The following is a description of a gene set: studied in species Homo sapiens Human Gene Set: REACTOME_REGULATION_OF_CDH11_GENE_TRANSCRIPTION Regulation of CDH11 gene transcription, and this is the list of marker genes: ZEB2, FOXF1, PRDM8, BHLHE22, HOXC8, SNAI1, ILF3, SP1, HEYL, CDH11